The following is a description of a gene set: Mouse Gene Set: GOMF_PROTEIN_ARGININE_OMEGA_N_ASYMMETRIC_METHYLTRANSFERASE_ACTIVITY Catalysis of the addition of a second methyl group to methylated peptidyl-arginine. Methylation is on the same terminal nitrogen (omega nitrogen) residue that was previously methylated, resulting in asymmetrical peptidyl-N(omega),N(omega)-dimethylated arginine residues. species: Mus musculus, and this is the list of marker genes: Prmt3, Prmt2, Mettl23, Prmt1, Prmt6, Prmt8, Carm1